Given this list of marker genes NPY5R, MIR302E, NPY, SELENOS, FCGR2B, SPN, IL20RB, here is a description of the gene set: Human Gene Set: GOBP_NEGATIVE_REGULATION_OF_ACUTE_INFLAMMATORY_RESPONSE_TO_ANTIGENIC_STIMULUS Any process that stops, prevents, or reduces the frequency, rate, or extent of an acute inflammatory response to an antigenic stimulus. species: Homo sapiens